The following is a description of a gene set: Any process that modulates the rate, frequency, or extent of the controlled release of molecules that form the extracellular matrix, including carbohydrates and glycoproteins by a cell or a group of cells. studied in species Mus musculus Mouse Gene Set: GOBP_REGULATION_OF_EXTRACELLULAR_MATRIX_CONSTITUENT_SECRETION, and this is the list of marker genes: Notch1, Adtrp, Tnfrsf1a, Agt, Tnfrsf1b (NCBI Gene Id 21938), Ier3ip1, Ric1, Cpb2, Rgcc, Bmp2